The following is a description of a gene set: species: Homo sapiens Contemporary treatment of pediatric acute myeloid leukemia (AML) requires the assignment of patients to specific risk groups. To explore whether expression profiling of leukemic blasts could accurately distinguish between the known risk groups of AML, we analyzed 130 pediatric and 20 adult AML diagnostic bone marrow or peripheral blood samples using the Affymetrix U133A microarray. Class discriminating genes were identified for each of the major prognostic subtypes of pediatric AML, including t(15;17), t(8;21), inv(16), MLL chimeric fusion genes, and cases classified as FAB-M7. When subsets of these genes were used in supervised learning algorithms, an overall classification accuracy of more than 93% was achieved. Moreover, we were able to use the expression signatures generated from the pediatric samples to accurately classify adult de novo AMLs with the same genetic lesions. The class discriminating genes also provided novel insights into the molecular pathobiology of these leukemias. Finally, using a combined pediatric data set of 130 AMLs and 137 acute lymphoblastic leukemias, we identified an expression signature for cases with MLL chimeric fusion genes irrespective of lineage. Surprisingly, AMLs containing partial tandem duplications of MLL failed to cluster with MLL chimeric fusion gene cases, suggesting a significant difference in their underlying mechanism of transformation. Human Gene Set: ROSS_ACUTE_MYELOID_LEUKEMIA_CBF from publication Ross ME, Mahfouz R, Onciu M, Liu HC, Zhou X, Song G, Shurtleff SA, Pounds S, Cheng C, Ma J, Ribeiro RC, Rubnitz JE, Girtman K, Williams WK, Raimondi SC, Liang DC, Shih LY, Pui CH, Downing JR (PMID 15226186) Top 100 probe sets for core-binding factor (CBF) acute myeloid leukemia (AML): contains CBFB MYH11 or AML1 ETO fusions., and this is the list of marker genes: HLA-DPA1, TRH, EGFL7, TPSAB1, CLEC5A, SPARC, WFDC1, HOMER2, VAMP5, TPK1, HLA-DMB, HSD17B11, CRIP2, LAT2, DUSP6, SLC25A1, CIAO3, CCND3, TMEM43, EGLN1 (egl-9 family hypoxia inducible factor 1), JUNB, CD58, IL5RA, PURA, CD34, KDM4B, SIPA1L1, C11orf21 (NCBI Gene Id 29125), PGM1, TRIO, DEPTOR, POU4F1, CACNA2D2, C15orf39, BAALC, RCBTB1, PMAIP1, BLVRA, DNMT3B, HPGDS, CBFB, RHOB, NCALD, PI4KA, MKNK2, TBXA2R, ABR, PTGIR, ADCY7, MYH11, ADARB1, PTGER2 (NCBI Gene Id 63381), DEXI, WIPF1 (WAS/WASL interacting protein family member 1), DISC1, SYNGR1, TMEM268, ITGB4, MAN1A1, ROBO1, BAIAP3, HIF1A, TRIM8, CLIP2, RASA4, STK32B, IL15RA, ISG20, PRAME, RUNX1T1, MN1, SLC8B1, CIITA, PSD3, CAV1, HLA-DPB1, ATP2B4, GALNT14, CD52, HYAL2 (hyaluronidase 2), DUSP2, OGG1